The following is a description of a gene set: studied in species Homo sapiens Infertility Human Gene Set: HP_INFERTILITY, and this is the list of marker genes: BBS12, CCDC40, CATSPER2, CFAP65, DNAAF5, MOV10L1, KLHL10, RPGR, SYCP2L, DAZ1, HSF2BP, NDN, C14orf39, HYDIN, DNAAF6, TEKT3, CCDC62, SNRPN, PADI6, IFT172, CFAP300, DNAI1, PRLR, RSPH9, DNAAF11, SLC11A1, RBMY1A1, CDY2A, SNORD116-1, BBS4, MSH4, MCIDAS, AXL, MIF, SYCP2, NLRP5, STUB1, GNRHR, ZPBP, FCGR2A (Fc gamma receptor IIa), NR0B1, ODAD2, STK33, PATL2, FEZF1, MEIOB, DNAH5, ZMYND10, PSMC3IP, CFAP47, CT55, SOHLH1, TAF4B, SPACA1, CLDN2, CDC14A, STRC, IQCN, DNAAF1, WWOX, AR, SEPTIN12, BBS2, LHX4, GCM2, MAP2K1, CFAP58, DHH, NR3C1, BRWD1, ZSWIM7, CCDC34, AMHR2, SLC26A9, CEP290, VAMP7, GSTM3, KDM5D, PANX1, GATA4, CFAP251, BRDT, RPL10L, SDCCAG8, KASH5, TEX14, VCY, SNORD115-1, BBS7, SLC26A8, ACR, CEACAM3, M1AP, DNAL1, CDH23 (cadherin related 23), ASTL, DPY19L2, BBS1, CFAP298, DNAAF2 (NCBI Gene Id 55172), TTC8, DCTN4, SPRY4, CFTR, REC114, APOA1, WT1, NEK10, HMOX1 (NCBI Gene Id 3162), CFAP221, MSH5 (NCBI Gene Id 4439), DNAH7 (dynein axonemal heavy chain 7), BBIP1, CFAP74, HSD17B3, TERB2, CDY1, PPP2R3C, PROP1, DNAH1, DDX3Y, NPAP1, LRRC56, ZP2, TRIM32, DNALI1, CEP19, CYP17A1, HSFY1, FBXO43, DNAH17, ODAD4, NME5, TTC29, ODAD1 (NCBI Gene Id 93233), CFAP70, CCIN, FANCM, SRY, FOXJ1, KCNU1, BPY2, DZIP1, FKBP6, USP26, WEE2, TGFB1, OCA2, DNAH8, MKKS (MKKS centrosomal shuttling protein), DNAAF4, QRICH2 (NCBI Gene Id 84074), MNS1, SPINK2, RPS4Y2, BLM (BLM RecQ like helicase), GGPS1, ZP1, WDPCP (NCBI Gene Id 51057), SPATA16, RNF212, HJV, XKRY, MOS, ARMC2, NLRP2, FSHB, KPNA7, ACTL9, PDHA2, SERPINA1, AMH, POU1F1, TOP6BL, AIP (aryl hydrocarbon receptor interacting protein), PGR, AKAP3, POF1B, BMP6, BBS9, HESX1, EDNRA, NME8, DNAH10, CCDC39, LHCGR, WDR19, C2CD6, SLC6A14, CCDC141, OTX2, SOX3, CLCA4, FSIP2, ZP3, CFAP44, PNLDC1, MAP3K1, OFD1, WDR11 (WD repeat domain 11), CATSPER1, SOX9, GGN, CEP112, NPHP1, GCLC (glutamate-cysteine ligase catalytic subunit), DHX37 (NCBI Gene Id 84742), SIM1, CDC20, FIGLA, CATIP, RSPH3, DAZ4, TRIP13, SLC9A3, GALT, TEX15, TERB1, DUSP6, SPAG1, GPR101, FANCA, GAS2L2, DNAAF3, BBS10, USP9Y, CFAP43, PWRN1, STK36, CCDC146, SCLT1, CTNS, SYCP3 (synaptonemal complex protein 3), SCAPER, CYLC1, DNAJB13, MAGEL2, SPEF2, TTC21A, SHOC1, KCNN4, CFAP418, IFT27, SEMA3E, BTG4, DNAH2, PWAR1, SUN5, TSGA10, DNHD1, PTPN11, CCNO, BBS5, BRAF, GNRH1, SPAG17, SPATA22, XRCC2, STAG3, DNAH11, HLA-DQA1, ADGRG2, TTC12, TLE6, FOXL2, DRC1 (dynein regulatory complex subunit 1), GBA2, ARL6, SRA1, MKRN3, DAZ2, H6PD, HLA-DQB1 (major histocompatibility complex, class II, DQ beta 1), IFT74, HFE, LZTFL1, CHEK1, TEX11, NANOS1, GCNA (NCBI Gene Id 93953), MKS1, ODAD3, RSPH1, CEACAM6, MEI1, CFAP61, DNAH9, FGF17 (fibroblast growth factor 17), RSPH4A, GLI2, ACTL7A, HERC2, ZMYND15, STX1A, ATP7B, DNAI2, LRRC23, TUBB8, SSX1, PLIN1, DAZ3, AK7 (NCBI Gene Id 122481), TDRD9, ZFPM2, SYCE1, PMFBP1, CYP19A1, NR5A1, CFAP52, TSPY1, AURKC, ARMC12 (NCBI Gene Id 221481), ZFP36L2, PLCZ1, FOXA2